Given this list of marker genes SMCHD1, DUX4L1, DUX4, FRG1, DNMT3B (DNA methyltransferase 3 beta), here is a description of the gene set: Human Gene Set: HP_BEEVOR_S_SIGN Weakness of the inferior portion of the rectus abdominal muscle, which is ascertained clinically as follows. When a patient sits up or raises the head from a recumbent position, the umbilicus is displaced toward the head. This is the result of paralysis of the inferior portion of the rectus abdominal muscle, so that the upper fibers predominate pulling upwards the umbilicus. species: Homo sapiens Beevor's sign